Given this list of marker genes KLRD1, KLRF1, KLRC3, CTSW, IL2RB, GZMH, IL18RAP, NCR1, KLRB1, XCL1, GZMA, CD160, CD244, PRF1, FASLG, GZMB, KIR2DL4, NKG7, XCL2, KLRK1, here is a description of the gene set: species: Homo sapiens Genes up-regulated in natural killer cells. Human Gene Set: CURSONS_NATURAL_KILLER_CELLS A preliminary gene set was obtained by combining the CIBERSORT (LM22) and Tosolini et al (LM7) gene sets for natural killer (NK) cells, together with a selection of marker genes from mouse NK cell studies (Huntington gene lists). Genes were filtered using by using bulk RNA-seq (GSE60424; via differential expression between NK cells and other sorted blood cell populations) and single cell RNA-seq (GSE72056; comparing various percentile thresholds between immune cell subsets) to select genes with particularly high transcript abundance within NK cells. The resulting gene set was further filtered to remove any genes which also show moderate-high expression within solid tumor cell lines from the Cancer Cell Line Encyclopedia. Genes filtered at various steps are labelled in Table S1 from the original publication (see EXTERNAL_DETAILS_URL). For a graphical summary please refer to Supplementary Figure S2 from DOI: 10.1158/2326-6066.CIR-18-0500 from publication Cursons J, Souza-Fonseca-Guimaraes F, Foroutan M, Anderson A, Hollande F, Hediyeh-Zadeh S, Behren A, Huntington ND, Davis MJ (PMID 31088844)